The following is a description of a gene set: studied in species Mus musculus Any process that modulates the frequency, rate or extent of vascular endothelial growth factor receptor signaling pathway activity. Mouse Gene Set: GOBP_REGULATION_OF_VASCULAR_ENDOTHELIAL_GROWTH_FACTOR_RECEPTOR_SIGNALING_PATHWAY, and this is the list of marker genes: Mt3, Cadm4, Nrp1, Tek (NCBI Gene Id 99999), Fgf9, Kdr, Mmrn1, Dll1, Fgf10, Cd59a, Angpt1, Cnmd, Prkd2, Grb10, Mmrn2, Emilin1, Vegfb, Vegfd, Bmp4, Hhex, Tmem204, Robo1, Hif1an, Fgf18, Hif1a, Ptpn1, Dab2ip, Pdcd6, Prkcb, Epn2, Vegfc, Hgs, Myof (myoferlin), Fzd4, Nedd4